Given this list of marker genes Tbx21, Stat6, Il6ra, Shh, Il6, Ep300, Opa1, Tox, Cd69, Stat3, Otud5, Brd2, Tgfb1, Il23a, Brd4, Lgals1, Ly9 (lymphocyte antigen 9), Loxl3, Bcl2, Irf4, Foxp3, Mtor, Tnfsf18, Ctsl, Braf (Braf transforming gene), Cyld, Slamf6, Il4, Spn, Batf, here is a description of the gene set: Mouse Gene Set: GOBP_CD4_POSITIVE_OR_CD8_POSITIVE_ALPHA_BETA_T_CELL_LINEAGE_COMMITMENT studied in species Mus musculus The process in which an immature T cell commits to CD4-positive T cell lineage or the CD8-positive lineage of alpha-beta T cells.